Given this list of marker genes SMARCB1, ZFHX3, NMRK2, GDF3, SMARCC1, SRA1, MSTN (NCBI Gene Id 2660), ACTB, EID2B, TGFB1, BOC, MYOCD, TMEM182, CMTM5, SMYD1, SOSTDC1, ARID2, TBX3, HIF1AN, BTG1, ACTL6B, ANKRD2, SMARCD3, TNF, PPARD, AKIRIN1, IL18, PHF10, CAPN3, MYOD1, RANBP3L, PLCB1, KLHL41, ARID1A, IGFBP3, PBRM1, SMARCA2, BRD7, SMARCD1, SMARCC2, RBM24, CXCL9, LRRC8A, ZFP36L1, KAT5, DLL1, RIPOR2, MYF5, FLOT2, DDIT3, MYOG, ACTL6A, MUSTN1, ID3, BMP4, XKR8, SOX9, SOX4, CXCL10, NOTCH1, MEF2C, MBNL3, TNFSF14 (TNF superfamily member 14), PRICKLE1, MAP3K5, MIR199A1, ARID1B, MAPK14, CSRP3, DPF3, SOX8, CCL8, TRIP4, SMARCE1, MYF6, SMARCD2, SMARCA4, here is a description of the gene set: species: Homo sapiens Any process that modulates the frequency, rate or extent of myoblast differentiation. A myoblast is a mononucleate cell type that, by fusion with other myoblasts, gives rise to the myotubes that eventually develop into skeletal muscle fibers. Human Gene Set: GOBP_REGULATION_OF_MYOBLAST_DIFFERENTIATION